The following is a description of a gene set: from publication Gao S, Yan L, Wang R, Li J, Yong J, Zhou X, Wei Y, Wu X, Wang X, Fan X, Yan J, Zhi X, Gao Y, Guo H, Jin X, Wang W, Mao Y, Wang F, Wen L, Fu W, Ge H, Qiao J, Tang F (PMID 29802404) Human Gene Set: GAO_SMALL_INTESTINE_24W_C4_ENTEROCYTE_PROGENITOR_SUBTYPE_2 studied in species Homo sapiens, and this is the list of marker genes: DPEP1, ACP5, PLAGL2, CFB, AQP1 (aquaporin 1 (Colton blood group)), ALDOB, MS4A8, DPP4, GLRX, MYORG, ETNK2, PON2, TMEM144, ENPP7, NR0B2, MEP1A, RBP4, KEL, C8G, ABCC2, APOB, SULT1B1, MFSD2A, SMIM24, SLC7A7, ZDHHC12, ALPI, GCHFR, S100G, MST1, OCIAD2, CELP, NPL, GJB1, APOA4, SLC9A3-OT1, RNF186, SLC5A9, ANXA4, TGM2, SLC34A3, MAMDC4, UGT3A1, MUC13, TSPAN13, DAB1, STARD5, RNF128, FBP1, SLC6A19, PNP, FABP2, OSGIN1, MYO1A, ABRACL, AGT, TMEM86B, SERPINA4, AFP, IL22RA1, PRSS3, VTN, HHLA2, CNKSR1, PNCK, CFI, FAM110C, RGN, DDC, CTSA, TREH, RAB25, RARRES1, FAH, C11orf86, DOK7, ASAH1, IFI30, SEC11C, FBXO2 (F-box protein 2), SMIM1, APOC3, S100A9, TMT1B, EMB (embigin), AOC1, XPNPEP2, NAGS, CHST13, TM4SF20, GOLT1A, APOA1, ATP1B3, IL32, SLC46A3, RBP2 (NCBI Gene Id 5948), G0S2